The following is a description of a gene set: Mouse Gene Set: TABULA_MURIS_SENIS_THYMUS_IMMATURE_T_CELL_AGEING species: Mus musculus from publication Tabula Muris Consortium (PMID 32669714), and this is the list of marker genes: Rnf10, Rbm3, Txnip, Pdia3, Erdr1